The following is a description of a gene set: Mouse Gene Set: WP_OXIDATIVE_PHOSPHORYLATION Oxidative phosphorylation species: Mus musculus, and this is the list of marker genes: Atp5pf, Ndufb8, Ndufa8, Ndufa2, Ndufb9, Atp5po, mt-Nd1, Atp6ap1, Atp6ap2, mt-Nd3, Ndufa9, Atp5f1a, Ndufc1 (NCBI Gene Id 66377), Atp5mc3, Ndufv3, Ndufs8, mt-Nd2, Ndufa5, Ndufa11, Ndufv1, Ndufs2, Ndufb6, Ndufa4l2, mt-Nd6, mt-Atp6, Atp5pd, mt-Atp8, Atp5f1b, Gzmb, Ndufa6, Atp5mc1, Ndufb5 (NCBI Gene Id 99783), mt-Nd5, Ndufs7, mt-Nd4l, Ndufb10, Ndufs5, Atp5pb, Ndufb2, Dmac2l, Ndufs1, Ndufb7, Atp5mf, Ndufa10, Ndufa7, mt-Nd4, Atp5f1d, Ndufv2, Atp5f1e, Atp5mg, Ndufc2, Ndufs6, Ndufs4, Atp5mc2